The following is a description of a gene set: species: Homo sapiens Human Gene Set: ZHENG_CORD_BLOOD_C6_HSC_MULTIPOTENT_PROGENITOR from publication Zheng S, Papalexi E, Butler A, Stephenson W, Satija R (PMID 29545397), and this is the list of marker genes: KAT6A, TSC22D1, HLA-DRA, GADD45A, MEIS1, FOSL2, CEBPB, TSC22D3, SNX9, NAMPT, SPP1, SAMSN1, MLLT3 (NCBI Gene Id 4300), LINC-PINT, MAP3K8, LPAR6, MEG3, MT-ND5, PTPRC, STAT1, ZFP36L2, HIF1A, SMCHD1, IRAK3, GATA3, PIM3, HLA-DPA1, FTH1, ZNF331, HLA-E, TPM2, SELENOK, TNFRSF1B, PELI1, THEMIS2, CXCR4, SRGN, SAT1, ARPC5L, RIPK2, TACC1, IRF1, HLF, MT-ND2 (mitochondrially encoded NADH:ubiquinone oxidoreductase core subunit 2), MECOM, CCNY, MAFF, HLA-DMB, CRHBP, PREX2, TFPI, HLA-DQB1, CCNH, CD109, DDIT4, ALDH1A1, CD74 (NCBI Gene Id 972, CD74 molecule), EZR, BEX1, RANBP2, HLA-DRB5, AVP, PPP1CB, PRKCH, LIMCH1, DUSP2, TUBA4A, RNU2-63P, FOXO1, PABPC1, HLA-DPB1, ID2, NR4A1, MMRN1, DUSP1, WDR45B, NEAT1, CAVIN2, FAM3C, HLA-DQA1, AREG, TSPYL2, NR4A2, SLC2A3, TCF4, TAMALIN, GBP4, NFKBIA, LRRFIP1, USP36, MEF2C, SOCS2, RNF125, HMGA2, MAFG, HLA-DRB1, RILPL2